The following is a description of a gene set: Removal of PI3P and Atg8/LC3 after the closure of the phagophore and before the fusion with the endosome/lysosome (e.g. mammals and insects) or vacuole (yeast), and that very likely destabilizes other Atg proteins and thus enables their efficient dissociation and recycling. species: Mus musculus Mouse Gene Set: GOBP_AUTOPHAGOSOME_MATURATION, and this is the list of marker genes: Vps4b, Clec16a (NCBI Gene Id 74374), Rubcnl (RUN and cysteine rich domain containing beclin 1 interacting protein like), Snx14, Stx17, Chmp4c, Mcoln1, Map1lc3b, Lamp2, Calm1, Vps4a, Ubqln1, Tbc1d25, Adrb2, Chmp1b, Chmp2a, Epg5, Map1lc3a, Vps33a, Chmp1b2, Atg14, Irgm1, Chmp1a, Cln3, Tecpr1, Mfsd8, Fyco1, Chmp6, Chmp3, Atg12, Vps16, Gabarapl2, Lix1l, Smcr8, Calm2, Pik3r4, Vamp8, Becn1, Atp2a2, Snapin, Ubqln4, Gabarap, Phf23, Gabarapl1, Atg5, Chmp5, Chmp7, Igtp, Pik3c3, Chmp2b, Elp6, Lix1, Tmem39a, Tom1 (NCBI Gene Id 21968), Vmp1, Calm3, Vcp, Snap29, Rubcn, Chmp4b, Afg2b, Uvrag, Irgm2, Calcoco2